Given this list of marker genes Fbxw7, Ppm1b (NCBI Gene Id 19043), Eloc, Pds5b, Nufip2, Osbpl11, Hmgb3, Wipf1 (WAS/WASL interacting protein family, member 1), Fhl4, Ano5, Reck, Phf11b, Wapl, Eif5b, Sgk3 (NCBI Gene Id 72422), Casp2, Foxg1, Trmt9b, Nek9, Zeb2, Ckap4, Matr3 (NCBI Gene Id 69967), Pld5, Uba6, Elmod2, Mmp12, Rasa2, Hpse, Gtf3c4, Tbl1xr1, Rapgef2, Rap1b, Spag9, Sox5, Npc1, Efnb2, Shprh, Slc35a2, Thap1, Vash2, Ints8, Fndc3b, Phf11d, Tjp1, Adipor2, Rusc2, Gli3, Adamts8, Aff3, Zcchc24, Arid4b, Fez2, Map2, Adamts6, Mgp, Hspa13 (NCBI Gene Id 78846), Phactr3, Cntn4, Pkd1, Commd3, Dlc1, Phf11c, Pcdh19, Lhfpl6, Xkr8, Depdc1b, Gabpa, Sec23a, Ube3a, Myof, Zic3, Pi4kb, Nab1, Pom121l12, Wdr82, Lrrk2, Slc14a1, Golga7, Crtap, Bnc2, Pkia, Dek (NCBI Gene Id 67004), Desi2, Foxp1, Phtf2, Tmem200c, Mprip, Ttc14, Ypel2, Unc5d, Sik1, Mboat2, Egln1, Clasp1, Anln, Pcmtd1, Ntf3, Ago2, Cdk17, Cilk1, Tram1l1, Uqcc5, Gata4, Sema3f, Nova1, Zfp185, Ssr3, Plcl1, Ywhab, Rtf1, Ulk2, Mtmr6, Vash1, Crkl, Lrp1, Phf6, Nedd1, Cops8, Aldh1a7, Strap, Nova2, Mtfr1, Mospd2, Esrrg, Slit2 (NCBI Gene Id 338531), Gpr161, Igsf3, Poglut3, Ptpn14, Rnf169, Scd1, Tent4b, Tln1, Nanos1, Rab21, Ric1, Ets1, Rgl1, Slc1a2, Hook3, Immp2l, Arl5b, Hmbox1, Gpr158, Jun, Usp27x, Slc6a1, AI593442, Sec24a, Ddx3y, Slc10a4, Slk, Csnk1g3 (casein kinase 1, gamma 3), Ugt8a, Fam118b, Marchf8, Lats2, Nr5a2 (nuclear receptor subfamily 5, group A, member 2), Tsc22d1, Plpp3, Slc30a4, Ankrd44, Arhgap20, Itsn2, Zfp68, Ankrd45, Bag5, Cntn1, Cecr2 (NCBI Gene Id 76549), Mmd, Yipf5, Hipk1, Fut9, Ankrd40, Khdrbs1, Slitrk1, Sema6d, Syne1, Psip1, Clic4, Foxn2, Fhl1, Xkr4, Ncs1, Jazf1, Rdh10, Myb (myeloblastosis oncogene), Trim33, Scrt2, Gpm6a, Ccnj, Golga1, Mosmo, Il10, Sesn1, Rab11fip2, Rnd3, Tbc1d12, Mmgt1, Syde1, Dpy19l1, Ppm1f, Suz12, Tsc22d2, Polr1f, Asf1a, Dennd1b, Rims2, Scn5a, Ice2, Rbfox2, Hapstr1, Npy2r, Lrp1b, Sptssa (NCBI Gene Id 66149), Zfp217, Cnot6, Serinc1, Pgm2l1, Ptpn21, Ensa, Fli1, Pdik1l, Mtss2 (MTSS I-BAR domain containing 2), Ube2w, Hnrnpd, Gnai3, Myo9a, Sfxn1, Ppp1r18, Med13, Cdh20, Pfpl, Dach1, Ap1s2, Sh3gl1, Sfr1, Dnajb5, Chrdl1, Atl2, Gpatch8, Eif4e2, Col4a3, Ncoa7, Smim13, Hipk3, Synj1, Igsf10, Oat, Sulf1, Mtf2, Ppp1r3g, Msn, Dnajb6, Cert1, Fbxw11, Ccnyl1, Cep350, Mgat2, Slc38a2, Zfpm2, Paxip1, Evi5, Piga, Cbx3, Zfta, Errfi1, St6galnac5, Lamc1, Ppp4r1, Syncrip, Nr3c1 (NCBI Gene Id 14815), Clip1, Vat1l, Nup107, Map3k1, Zeb1, Qki, Pof1b, Eps8, Rbsn, Cd302 (NCBI Gene Id 98862), Tex2, Tfap2a, Elmod1, Srsf1, Prkg1, Ywhag, Stap1, Capn6, Arih1, Sox2, Asap1, Six1, Cnep1r1, Nck2, Nrbp1, Atp11c, Agfg1, Coro1c, Ranbp9, Obox5, Paip1, Nectin4, Xkr6, Arhgap6, Frmd6, Rps6kb1, Spryd7, Zfp871, Mindy2, Cfl2, Prr11, Phf11a, Nrf1 (NCBI Gene Id 97326), Amfr, Pik3ca, Tln2, Osgepl1, Fignl2, Zfp711, Cnot7, Slc23a2, Zfand6, Ptpn12, Dennd5b, Zfp131, Fbxo33, Ipo8, Tbk1, Hs3st1, Phc3, Clasp2, Taok1, Foxf1, Wasf1, Lce1c, Dennd5a (NCBI Gene Id 68963), Bap1, Ppp1r9b, Gpr75, Atxn1, Phf21b, Hdhd2, Csmd3, Pik3cb, Tubb5, Erg, Rap2c, Nfia, Trappc14, Tob1, Gtf2e1, Tbx5, Ngef, Oxr1, Bnip3l, Syvn1, Nbr1, here is a description of the gene set: Genes predicted to be targets of miRBase v22 microRNA mmu_miR_200b_3p, mmu_miR_429_3p in miRDB v6.0 with MirTarget v4 prediction scores > 80 (high confidence targets). species: Mus musculus Mouse Gene Set: MIR_200B_3P_MIR_429_3P from publication Chen Y, Wang X (PMID 31504780)